Given this list of marker genes SHANK3, AP3B2, TM6SF1 (transmembrane 6 superfamily member 1), SH3GL3, WHAMM, RAMAC, SPCS1, DNM3, SPCS3, RYR1, GOLGA6L4, RAF1, SHANK1, BTBD1, SLC2A1, AP3D1, GRM5, HTT, C15orf40, TOP1, PDE8A, ALPK3, MIR4515, SLC28A1, ZNF592 (zinc finger protein 592), SEC11A, SYNJ1, TENT4B, WDR73, AP3S1, AGAP2, ADAMTSL3 (ADAMTS like 3), RNMT, RYR2, NMBR, EGF, NMB, SPCS2, ITPR1, GRM1, ZSCAN2, BNC1, HOMER2, AP3M2, CPEB1, FSD2, here is a description of the gene set: Human Gene Set: WP_15Q25_COPY_NUMBER_VARIATION species: Homo sapiens 15q25 copy number variation